Given this list of marker genes GUK1, AK5, DTYMK, CMPK2, NUDT18, here is a description of the gene set: The chemical reactions and pathways involving a deoxyribonucleoside diphosphate, a compound consisting of a nucleobase linked to a deoxyribose sugar esterified with diphosphate on the sugar. Human Gene Set: GOBP_DEOXYRIBONUCLEOSIDE_DIPHOSPHATE_METABOLIC_PROCESS studied in species Homo sapiens